Given this list of marker genes LEF1, SIRT1, CBLL1, NT5C3A, FHIP2A, PHF1, SAMHD1, RBM15B, CLTA, KMT2A, TNXB, BLTP1, UBR4, RNF103, ZW10, TSSK6, TXK (NCBI Gene Id 7294), BACH2, CDC37, TMED7, ST8SIA4, TUBB2A, METTL3, IPO9, JADE1 (jade family PHD finger 1), KAT7, PRKD3, AAK1, SLC7A2, TOX4, FUBP1, IGF2R, SF1, SMC5, USP24, AGTPBP1, UBE2E3, SELL (NCBI Gene Id 6402), FBXL12 (NCBI Gene Id 54850), SMC4, RBM6, CRHR1, SLC12A6, TCF12, WDR26, SENP2, BRWD1, SPP1, TBX21, REV1, PAG1, CROT, CBX2, REXO4, MCOLN3, CD28, CSPP1, IFT80, TASOR2, GLG1, RBM39, RCN2, HNRNPA2B1, HAAO, SOAT1, ZNF326, PRP4K, CLK4, BICD2, LGMN, SESN3, DPH2, GCNT3, BCAP31, FOXO1 (forkhead box O1), NR3C1, SOX4, KDM5B, GNG12, SYTL2, TSSK2 (testis specific serine kinase 2), SLC27A4, ITK, ADCY6, TGFBR1, ACTR6, ZC3H10, TLE4, TASP1, CNN3, NEDD4 (NEDD4 E3 ubiquitin protein ligase), SEPTIN4, FAM32A, JMJD1C, UFSP1, JAK1, TLR7, NUP58, PCID2, FAM8A1, KANSL2, SLC30A9, VPREB1, IFNG, RNF166, AKR7A2, RFTN2, VAMP4, PARG, ST3GAL6, PENK, HERC1, TEDC1, TTC3, RGL3 (ral guanine nucleotide dissociation stimulator like 3), NEDD9, SLC6A20, STK24, NRDC, TRIM59, MAGT1, SMC6, RBL2, ALCAM, CD7, FAM118B, MAP3K3, GABARAPL2, WSB1, ASB13, YTHDC1, NFX1, ATP1B1, SLC35D1, RAPGEF6, REG3G, STAG2, DMXL1, SRPK1, ZNF280D, CAMK4, C1orf159, PCMTD2, ETAA1, C1orf54, SLC2A3 (NCBI Gene Id 94827), NXF2, CRYBG1, AQP9, LZTR1, ETNK1, TRRAP, PRODH, NRP1, BCL9L, RBMS2, TMEM168, CHTOP, SORCS2, DDIT3, SATB1, MCM3AP, DCX (NCBI Gene Id 1641), APOBR, NRIP1, TKTL1, CDK2AP2, SP3, EDRF1, MYCBP2, IRF4, MISP, CSTF2, KLRG1, BABAM2, FSIP1, ZNF638, SPCS2, KCNJ8, DIP2B, USP34, TAX1BP1, TLK2, KLF3, ITM2A, KCTD12, SAMSN1, TRIO, SH2D1A, ORC4, TRIM39, EYA4 (NCBI Gene Id 56002), CCDC71L, CHDH, ADCY9, PKNOX1, ID3, GRAMD1A (GRAM domain containing 1A), TPRG1L, DXO (NCBI Gene Id 1797), here is a description of the gene set: studied in species Homo sapiens from publication Baek D, Villén J, Shin C, Camargo FD, Gygi SP, Bartel DP (PMID 18668037) Human Gene Set: GSE12003_MIR223_KO_VS_WT_BM_PROGENITOR_4D_CULTURE_UP Genes up-regulated in 4 day cultures of bone marrow progenitors: wildtype versus MIR223 knockout. This array analysis is to study developmental time course of the regulation of target messages’ expression during culture of murine neutrophils versus miR-223 null neutrophils. Culture media was SILAC-IMDM for MS analysis.